Given this list of marker genes Gabra6, Fgf13, Cbln1, Plxnb1, Gabrb3, Gabra1, Mdga1, Gabrg1, Gabra5, Hapln4, Gabra4, Npas4, Gabra3, Sema4a, Cbln4, Gabrg2, Sema4d, Lhfpl4, Gabrg3, Gabrb2, Gabra2, Gabre, Clstn2, Srgap2, Nlgn2, Clstn3, Cntnap2, Lgi2, here is a description of the gene set: Mouse Gene Set: GOBP_INHIBITORY_SYNAPSE_ASSEMBLY species: Mus musculus The aggregation, arrangement and bonding together of a set of components to form an inhibitory synapse.